Given this list of marker genes FOXE1, CRKL, WNT9B, INSIG2, MEGF8, B3GLCT, SMAD2, CEP55, NODAL, LHX1, DCANP1, RUNX2, TIFAB, TGFBR1, TBX1, PRRX1, CHST11, CTNNB1, PAX5 (paired box 5), NEUROG1, HOXA1, WDR19, MTHFD1L, MED12, SLC39A3, FGF8, RDH10 (retinol dehydrogenase 10), SIX4, LRP2, FOXC2, SIX1, COLEC10 (NCBI Gene Id 10584), IRF6, TBX15, FREM1, FGFR2, MSX2, TFAP2A, PDGFRA, HOXA2, GLI3, TGFBR2, GNA11, RAB23, GRHL2, TMEM107, EDNRA, INSIG1 (insulin induced gene 1), FGF4, SMAD3, MTHFD1, TGFB2, MMP14, MMP16, TGFB1 (NCBI Gene Id 7040), CPLANE2, EXT1, RIC1, BMP4, DLX2, EIF4A3, SIX2, TWIST1, IFT140, ZIC3, SLC39A1, FOXN3, NDST1, TULP3, NIPBL, IRX5, NOG, TP63, here is a description of the gene set: species: Homo sapiens Human Gene Set: GOBP_CRANIAL_SKELETAL_SYSTEM_DEVELOPMENT The process whose specific outcome is the progression of a cranial skeletal system over time, from its formation to the mature structure. The cranial skeletal system is the skeletal subdivision of the head, and includes the skull (cranium plus mandible), pharyngeal and/or hyoid apparatus.